Given this list of marker genes Grik2, Cpt1c, Htr3a, Gria1, Shisa9, Dlg3, Cnih3, Grik1, Grid2, Cacng4, Gria4, Grin2a, Ptk2b, Cacng3, Shisa7, Cacng8, Grin2b, Grik3, Grin2d, Grin2c, Grin3a, Abhd6, Lrrtm4, Cacng7, Grik4, Grin1, Vwc2 (NCBI Gene Id 319922), Gria3, Eps8, Abhd12, Porcn, Cacng2, Cacng5, Grid1, Olfm2, Sacm1l, Gria2, Vwc2l, Htr3b, Grik5, Shisa6, Dlg4, Shisa8, Olfm1, Olfm3, Nrn1, Grin3b, Cnih2, here is a description of the gene set: studied in species Mus musculus Any protein complex that is capable of functioning as a neurotransmitter receptor. Mouse Gene Set: GOCC_NEUROTRANSMITTER_RECEPTOR_COMPLEX